Given this list of marker genes RXRB, CYP27B1, MN1, VDR, TRIM24, SNAI2, MED1, SNW1, KANK2, RXRA, here is a description of the gene set: Any process that modulates the frequency, rate or extent of vitamin D receptor signaling pathway activity. studied in species Homo sapiens Human Gene Set: GOBP_REGULATION_OF_VITAMIN_D_RECEPTOR_SIGNALING_PATHWAY